The following is a description of a gene set: part of: Pyruvate metabolism The mitochondrial pyruvate dehydrogenase complex catalyzes the reaction of pyruvate, CoASH, and NAD+ to form acetylCoA, CO2, and NADH. The enzyme complex contains multiple copies of E1 alpha, E1 beta, E2, and E3, each with distinct catalytic activities, and the X-component (PDHX) which is required for anchoring E3 to E2. The reaction starts with the oxidative decarboxylation of pyruvate catalyzed by E1 alpha and beta (pyruvate dehydrogenase). Lipoamide cofactor associated with E2 is reduced at the same time. Next, the acetyl group derived from pyruvate is transferred to coenzyme A in two steps catalyzed by E2 (DLAT, dihydrolipolyl transacetylase). Finally, the oxidized form of lipoamide is regenerated and electrons are transferred to NAD+ in two steps catalyzed by E3 (DLD, dihydrolipoyl dehydrogenase). The biochemical details of this reaction have been worked out with pyruvate dehydrogenase complex and subunits purified from bovine tissue and other non-human sources. Direct evidence for the roles of the corresponding human proteins comes from studies of patients expressing mutant forms of E1 alpha, E1 beta, E2, and E3. The most common PDH complex deficiencies are caused by defects in PDHA and PDHX but can be caused by defects in any component of the complex (e.g. Pavlu-Pereira et al., 2020; reviewed in Prasad et al., 2011). species: Homo sapiens Reactome Pathway: PDH complex synthesizes acetyl-CoA from PYR, and this is the list of marker genes: DLAT, PDHA1, PDHA2, PDHX, PDHB, DLD